The following is a description of a gene set: A process, occurring in the muscle, that is characterized by a decrease in protein content, fiber diameter, force production and fatigue resistance in response to different conditions such as starvation, aging and disuse. Human Gene Set: GOBP_MUSCLE_ATROPHY studied in species Homo sapiens, and this is the list of marker genes: NOL3, CFLAR, TRIM63, ACTN3, FOXO3, MSTN, GSN, MYOG, ASB2, GATM, TBCE